Given this list of marker genes PPP3CB, DSEL, UBE2Q2, AHDC1, FAM9B (NCBI Gene Id 286476), RELN, TMEM151B, TMEM131L, here is a description of the gene set: Human Gene Set: MIR5092 species: Homo sapiens Genes predicted to be targets of miRBase v22 microRNA hsa-miR-5092 in miRDB v6.0 with MirTarget v4 prediction scores > 80 (high confidence targets). from publication Chen Y, Wang X (PMID 31504780)